Given this list of marker genes WDR77, CLNS1A, HSPE1, SSH2, NDUFS5, VAMP1, GLT8D1, GDE1, RNPEPL1, SLC35E2B, BBS12, UPB1, PDF, ZBTB22, KCTD2, TBC1D14, HOOK3, TSC1, ERBB3, MAP4K4, ATG10, CCDC93, PEBP1, RSU1, FBL, MBNL1, HHEX, PAFAH1B3, PPP1CC, SERP1, ABLIM1, FH, PPP1R21, SIN3A, TOR4A, PLP2, SH2B2, ZMYM5, SLC25A51, POP5, TCF20, CISD1, DBP, NBEAL2, MRPS35, TP53INP1, RNF187, FGD2 (NCBI Gene Id 221472), ZBTB45, COASY, RBL2, HPS4, VKORC1, ZPR1, EIF4B, YY1, METTL23, DCAF5, RNASET2, ANAPC7, HCFC1, SLAIN2, TBXA2R, SGSH, LSM10, MBD1, CBX3, DIPK1A, MCFD2, RMND5B, CASD1, SMAP2, TMEM109, ME2, FASN (NCBI Gene Id 2194), TNFAIP8L2, HGSNAT, DDX51, GLTP, SYNRG, SEC22C, GPAM, SDF2, RIC8B, HVCN1, GBE1, CD300C, ACAP1, ATP6V0E1, CETN2, RSPH3, ARHGAP11A, DESI1, PDE4DIP, TTF2, C6orf89, ARHGAP45, TMED10, GALNT1, ECH1, TMEM179B, SLC1A5, UPF3B, CPSF3, ZXDB, YPEL3, NCBP2, PCMTD2 (protein-L-isoaspartate (D-aspartate) O-methyltransferase domain containing 2), NIPAL3, ACBD5, POLR2J, NDUFB11, SLA, MYO18A, FBXO22, MINDY2, IFT172 (intraflagellar transport 172), TOP1MT, HSBP1, MSRB2, GIT2, NCKAP1L, ASXL2, EML3, LIME1, HNRNPUL1, WDR7, SLC25A36, UNG, TMEM147, STYX, YPEL5, SP3, PON2, IFFO1, TEDC2, NXPE4, CTDSP2, FMO5, P2RY6, SETD7, LSP1, HECTD3, UBN1, EPHB2 (NCBI Gene Id 50980), PYCR2, HPSE, AKAP11, PRKACB, ERMP1, PRMT9, TMEM126A, BTBD1, TMEM86A, IRF3, CD79B, FBXL14, RIF1, SLC46A3, NNT, GXYLT1, ARMC10, PMS2, AGL, DYNLT1, SP1, GPD1L (NCBI Gene Id 23171), DDRGK1, CCDC47, RAB40C, LGALS4, TTC13, PANX1, OSBPL9, RGS19, ZBTB14, PINK1 (NCBI Gene Id 65018), FAM168A, ADAM11, UBE4B, GNG10, PFAS, PRMT3, HPS3, ITGB3, CDC42SE2 (CDC42 small effector 2), XPO7, GUCD1, NDUFS8, ARL6, PRUNE1, SMIM5, CDIP1, SNX15, SH3BP1, ANKDD1B, TSPYL4, ATG16L2, BMF, EOLA1, here is a description of the gene set: Genes up-regulated in at day 0 B cell IRF4-KO versus CD40L and IL-2 IL-4 IL-5 stimulated at day 3 B cell IRF4intermediate. from publication Ochiai K, Maienschein-Cline M, Simonetti G, Chen J, Rosenthal R, Brink R, Chong AS, Klein U, Dinner AR, Singh H, Sciammas R (PMID 23684984) studied in species Homo sapiens Temporal analysis of B cell activation in vitro using CD40L and IL-2/4/5 cytokines in wild type Irf4+/+ B cells or in mutant Irf4-/- B cells harboring a tet-inducible allele of Irf4. IRF4 expression was restored, or not, in the Irf4-/- background by culturing in the presence of low or high concentrations of doxycycline. The results provide insight in the role of IRF4 expression levels in coordinating different programs of B cell differentiation. Human Gene Set: GSE46606_UNSTIM_VS_CD40L_IL2_IL5_3DAY_STIMULATED_IRF4MID_SORTED_BCELL_UP